Given this list of marker genes Slc25a5 (solute carrier family 25 (mitochondrial carrier, adenine nucleotide translocator), member 5), Slc25a4, Bak1, Slc35f6, Fzd9, Gclc, Ier3, Mpv17l, Slc25a31, Bcl2l1, Acaa2, Bok, Tmem14a, here is a description of the gene set: Any process that stops, prevents or reduces the frequency, rate or extent of mitochondrial outer membrane permeabilization involved in apoptotic signaling pathway. studied in species Mus musculus Mouse Gene Set: GOBP_NEGATIVE_REGULATION_OF_MITOCHONDRIAL_OUTER_MEMBRANE_PERMEABILIZATION_INVOLVED_IN_APOPTOTIC_SIGNALING_PATHWAY